The following is a description of a gene set: Cells from four develppmental stages were purified by FACS from human bone marrow samples studied in species Homo sapiens Human Gene Set: GSE4590_SMALL_VS_LARGE_PRE_BCELL_DN from publication Hoffmann R, Lottaz C, Kühne T, Rolink A, Melchers F (PMID 17890238) Genes down-regulated during B lymphocyte differentiation: small pre-B II versus large pre-B II., and this is the list of marker genes: CACNB1, TMEM71, KLF8, CCR7, NDRG1, NFATC2, RARA, SMAP2, VIM, CTNNA1, SPATA6, SMAD7, GRAP, METTL15, AHNAK, MAPK12, DOCK5 (NCBI Gene Id 80005), LGALS3, CDC42SE2, EPCAM, DYRK3, DNAAF4, ZNRF2, PAQR8, CAPN5 (calpain 5), ANKRD45, DNAJC4, S100A6, DEGS1, AQP1, TDRD7, DUSP7, LINC-PINT, PMAIP1, PRRG4, SEMA6A, PACSIN1 (NCBI Gene Id 57564), RPA1, PLP2, EBI3, RGL1, BBS2, SLC25A24, FCGRT, CCR6, HOOK2, GIMAP4, KCTD14, DTD1, FXYD5, ILDR1, GIMAP3P, KLF12, KLF4, SELL, LGALS1 (NCBI Gene Id 3956), ANXA7, SQOR, PDE4B, BTN2A2, SMAD1, RBM11, MICU2, CTDSPL2, NOD1, PNMA8B, GMFG, UAP1, NECTIN1, ANXA2, GRK3, PRSS16, AIDA, SMPDL3A, CEP170B, CNR1, AVPI1, CAND2, BTNL2, CKAP4, SEPTIN10, RCAN2, ZFP36L2, DUSP3, EXPH5, MAT2B (methionine adenosyltransferase 2 non-catalytic beta subunit), XYLB, CD99L2, CDK19, AKT3, PLIN3, ADRB2, ACADM, TAGAP, FHL3, SPINT2, SEC24D, PGLYRP1, GLIPR2, PIK3IP1, CRTAP, RAB27A, SEC16B, JCHAIN, DIPK1A (divergent protein kinase domain 1A), TNNT3, RBPMS (RNA binding protein, mRNA processing factor), CD69, EIF4E3, ELF3, CMPK2, SRMS, BHLHA15, ATP9A (NCBI Gene Id 654090), MARVELD2, FAM107B, RFLNB, SIT1, PDLIM1 (NCBI Gene Id 9124), HEXB, COL6A4P1, KCNH5, GRB7, DRC7, L1CAM, RASGRP4, GULOP, CNN3, GAD1, LIPT1 (lipoyltransferase 1), ARHGAP26, DKKL1, TSC22D3 (NCBI Gene Id 64477), FNDC11, RNF144A, CMTM4, SLC2A6, DLGAP4, WSCD2, TRDMT1, PALS2, SPN, PPP2R5C (NCBI Gene Id 63377), RAP1GAP2, PYM1, CPNE4, ANXA5, GGCT, RAD18, PRR36, SLC29A4, ITGB7, CD80, CCDC57, ARHGAP8, FAM114A1, TES, NFKBIA (NFKB inhibitor alpha), LRRC8C, GLOD4